Given this list of marker genes CLDN23, ACSL1, MAF1, LRRC8C, RFX5, SLAMF8, GBP6, PCYT1A, GTF2F1, GPRIN1, RBM15, HCFC1R1, COG4, TNFSF4 (TNF superfamily member 4), PLEKHO1, PLPP2, DSPP, ISG15, DGKA, RIPK2, CMTM3, SFN, TENT2, BFAR, MAU2, ING2, GPRC5B, ANKRD27, AP3M2, NAPSA, RASA4, PTTG1, PKLR, CDON, CEMIP, ILRUN, CLK3, ANO10, USP47, TIMM10B (NCBI Gene Id 26515), C9orf78, PLA2G7, SLAMF7, BCAR3, SULT1E1, SAT1, THSD1, NSUN4, PMF1, SEH1L, PRMT2, AP3B1, SPMIP5, DNASE1L3, TSPAN17, IL12RB1, REST, MALAT1, EXOC7, PTGS1, IDNK, SHARPIN, CDC42EP4, IKZF2, FNBP4, SLC12A9, CDYL, ADAP2, CAMLG, CREBRF, ARL4C, PDCD2, RRAGD, ZNF704, SPSB4, OAF, KEAP1, P2RY14, KAT2B, RGS14, ASB3, CTDNEP1, PTPN2, BRMS1, GRIN2D, ENKD1, PGM1, CUBN, DGLUCY, DYNLT4, SPDL1 (spindle apparatus coiled-coil protein 1), TGFA, PAXBP1, TPRA1, ANXA11, PGLYRP1, HEBP1, EHD2, TLE2, HINFP, HNF1A, CBY2, KLF15, TAPBP, C3orf62, RBBP8, SLFN12, EPSTI1, ADGRV1, KIF9, SLU7, PNPT1, PCDHB2 (protocadherin beta 2), RAB43, VPREB3, ZBTB2, NLGN2, FAM120A, PCSK1, POU2F1 (POU class 2 homeobox 1), GUK1, LARGE1, WEE1, ATP6V0A4, ASB11, KDM3B, TMEM229B, EPB41L5, CARS1, IRF7, RAB22A, GMPPB, TDRD1, RNF115, CPSF4L, GRIN2C, SYT5, TSC22D3 (NCBI Gene Id 64477), DNAJB7, CLDN15, RABEP2, SESN2, C11orf96, MED12, OR11H4, TMEM51, ADNP, LPXN (NCBI Gene Id 9404), LAT, DUSP7, MX2, DIO2, PAG1, ST6GALNAC4, PHF13, MAP6, KLF2, NTS, SDF2, FBN2, SFMBT1, POU1F1, TLR9, MINK1, TOR2A, UTRN, CD300LF, MDM2, SPOP, ARL4A, CD86, CCDC92, MTMR14, YPEL1, DRC3, RCHY1, ATP1B3, RARG, OCA2, MCOLN3, SUN2, RASA3, NXPH1, MKI67 (marker of proliferation Ki-67), CD274, RALBP1 (ralA binding protein 1), CHRNA6 (NCBI Gene Id 8973), CAMK2D, PTS, USP12, PLEKHF2, MIIP, NUDT13, EGR4, PIK3C2G, FAM210B, GUCD1, PTGDR2, FBXO25 (F-box protein 25), SEC16B, here is a description of the gene set: from publication Amit I, Garber M, Chevrier N, Leite AP, Donner Y, Eisenhaure T, Guttman M, Grenier JK, Li W, Zuk O, Schubert LA, Birditt B, Shay T, Goren A, Zhang X, Smith Z, Deering R, McDonald RC, Cabili M, Bernstein BE, Rinn JL, Meissner A, Root DE, Hacohen N, Regev A (PMID 19729616) mouse primary BMDCs were stimulated with tlr ligands and gene expression changes were profiled on Affymetrix arrays Human Gene Set: GSE17721_POLYIC_VS_GARDIQUIMOD_12H_BMDC_UP Genes up-regulated in comparison of dendritic cells (DC) stimulated with poly(I:C) (TLR3 agonist) at 12 h versus DC cells stimulated with Gardiquimod (TLR7 agonist) at 12 h. species: Homo sapiens